Given this list of marker genes KIFAP3, LBH, BEX1, RXRG, BIN1, CAVIN4, ATP1A3, CMTM7, GPR22, IGFBP7, VCAN (versican), TXNIP, ECI1 (NCBI Gene Id 1632), S100A4, HEY2, C7, CCDC34, GPRIN3, PYGM, MASP1, PYGL, KLHDC8B, ISYNA1, LINC01405, DGCR6, CD24, here is a description of the gene set: Human Gene Set: CUI_DEVELOPING_HEART_RIGHT_VENTRICULAR_CARDIOMYOCYTE species: Homo sapiens from publication Cui Y, Zheng Y, Liu X, Yan L, Fan X, Yong J, Hu Y, Dong J, Li Q, Wu X, Gao S, Li J, Wen L, Qiao J, Tang F (PMID 30759401)